The following is a description of a gene set: electronically inferred by orthology from the curated human pathway studied in species Mus musculus part of: RUNX2 regulates bone development This event has been computationally inferred from an event that has been demonstrated in another species.<p>The inference is based on the homology mapping from PANTHER. Briefly, reactions for which all involved PhysicalEntities (in input, output and catalyst) have a mapped orthologue/paralogue (for complexes at least 75% of components must have a mapping) are inferred to the other species. Reactome Pathway: RUNX2 regulates osteoblast differentiation, and this is the list of marker genes: Runx2, Ar (androgen receptor)